The following is a description of a gene set: Human Gene Set: REACTOME_TRANSFERRIN_ENDOCYTOSIS_AND_RECYCLING Transferrin endocytosis and recycling studied in species Homo sapiens, and this is the list of marker genes: ATP6V1F, ATP6V0A1, ATP6AP1, ATP6V1E2, ATP6V1B2, TFRC, TF, STEAP4, TFR2, ATP6V0D2, ATP6V0A4, ATP6V0E1, ATP6V1G2, ATP6V0E2, ATP6V1H, STEAP3, ATP6V0C, TCIRG1, ATP6V1B1, ATP6V1C2, ATP6V1E1, HFE, ATP6V0A2, ATP6V1G1, MCOLN1, ATP6V1A, ATP6V1C1, ATP6V0D1, ATP6V0B, ATP6V1G3, ATP6V1D